Given this list of marker genes Kcnn4, Mmp8, Ctsc, Plcg2, Tafa3, Trem2, Csf1r, Lrrk2, Stap1, Nupr1, Ttbk1, here is a description of the gene set: Mouse Gene Set: GOBP_POSITIVE_REGULATION_OF_NEUROINFLAMMATORY_RESPONSE studied in species Mus musculus Any process that activates or increases the frequency, rate or extent of neuroinflammatory response.